The following is a description of a gene set: Binding to the oxidized form, FAD, of flavin-adenine dinucleotide, the coenzyme or the prosthetic group of various flavoprotein oxidoreductase enzymes. Mouse Gene Set: GOMF_FAD_BINDING species: Mus musculus, and this is the list of marker genes: Acoxl, Acox1, Cyb5r3, Mical3, Ndor1, Steap4 (STEAP family member 4), Mical1, Gulo, Dpyd, D2hgdh, Cry1, Qsox1, Mtrr, Mmachc, Kmo, Aox3, Sqle (NCBI Gene Id 20775), Cybb, Cry2, Aox2, Kdm1b, Txnrd1, Mical2, Aox4, Ero1a, Xdh, Prodh2, Sqor, Acox3, Dhcr24, Ddo, Nqo2, Ero1b, Acox2, Agps, Aox1 (aldehyde oxidase 1), Steap3, Cyb5r2, Aifm1, Coq6, Cyb5r1, Pcyox1, Dao, Prodh, Ldhd, Mthfr